Given this list of marker genes Ankrd24, Tprn, Nherf1, Strc, Fgfr1, Sec24b, Sod1, Ush1c, Rac1, Pdzd7, Tmc1, Scrib, Atp2b2, Rest, Clrn2, Pcdh15, Myo3b, Triobp, Pafah1b1, Grxcr1, Tomt, Slc4a7 (solute carrier family 4, sodium bicarbonate cotransporter, member 7), Mir96, Myo3a, Wdpcp, Lhfpl5, Cdh23, Alg10b, Kcnq1, Myo7a, Pls1, Ripor2, Grxcr2, Slitrk6, Tecta, Whrn, Clic5, Clrn1, Elmod3, here is a description of the gene set: Mouse Gene Set: GOBP_AUDITORY_RECEPTOR_CELL_DEVELOPMENT The process whose specific outcome is the progression of an auditory receptor cell over time, from its formation to the mature structure. Cell development does not include the steps involved in committing a cell to a specific fate. studied in species Mus musculus